The following is a description of a gene set: The end of a microtubule that does not preferentially grow (polymerize). Mouse Gene Set: GOCC_MICROTUBULE_MINUS_END studied in species Mus musculus, and this is the list of marker genes: Svil, Aspm, Camsap3, Camsap1, Camsap2, Abraxas2, Numa1